Given this list of marker genes Acvr2a, Inhba, here is a description of the gene set: electronically inferred by orthology from the curated human pathway part of: Signaling by TGFBR3 This event has been computationally inferred from an event that has been demonstrated in another species.<p>The inference is based on the homology mapping from PANTHER. Briefly, reactions for which all involved PhysicalEntities (in input, output and catalyst) have a mapped orthologue/paralogue (for complexes at least 75% of components must have a mapping) are inferred to the other species. Reactome Pathway: TGFBR3 regulates activin signaling studied in species Mus musculus